Given this list of marker genes BMAL1, HDAC3, KIF2C, GADD45A, PRDM11, WIZ, TMOD3, BTG4, ZNRF4, EIF2AK4, RB1, YEATS4, MOS, INHBA, FOXO4, SIRT1, BTRC, RHOB, CEP131, RPS15A, AATF, DR1, ZMPSTE24 (NCBI Gene Id 10269), BUB1 (NCBI Gene Id 699), OOEP, DDRGK1, CALM2, PRPF19, MIR221, RAD9B, TERF2, KANK2, MIR195, RAD9A, SMARCC2, AVEN, PTPRK, INSR, RPRD1B, DYNC1H1, CEP295, SSTR5, KLHL22, DDIT3, ANKRD31, PRC1, RACGAP1, NR2E1, MX2, CDK5, TGFA, CDK8, WDR5, FOXC1 (forkhead box C1), MEIOSIN, TTK, NEK2, ATM, PRPF40A, WEE2 (NCBI Gene Id 494551), NEK10, RAB11FIP3, TP53BP1, PKD2, MIR519D, SPAG5, NDC80, MACROH2A1, MSX2, MIR892B, VPS4B, RBM46, FOXG1, BCL6, SASS6, USP2, TMEM8B, TFDP1, MIR15B, APBB1, CCNE2, FGFR1, E2F8, HNRNPU, DYRK3, CTBP1, CDC45, FAM107A, SENP6, OBSL1, MIR520H, MAD2L2, GPR132, ADAMTS1, TIPIN, TPRA1, RAE1, KIF23, STOX1, ZNF703, BABAM2, PSME3, PTEN, AMBRA1, CCPG1, ZWILCH (NCBI Gene Id 55055), CDC25B, EDN1, KNL1, DOT1L, ZNF207, CSNK2A1, PPP1R15A, ZFYVE26, TICRR, MIR29C, SKA1, MBLAC1, RAD51B, ERCC6, MIR372, TOPBP1, CLTC, MRFAP1L2, GIPC1, PLCB1, EXOC7, CDC73, TADA2A, PRDM9, RCC2, TBX3, CABLES1, NOP53, IQGAP1, MEPCE, INSM1, HMGA2, BCL7C, OPN1LW, CAMSAP3, ITGB1, SLF2, MEIOC, INIP, ACTL6A, MAPK14, TBRG4, RGCC, BID (BH3 interacting domain death agonist), SOX2, RBM14, PIK3C3, PTPRC, TACC3, KLF4, RRM2, KAT5, PCLAF, CDKL1, ALOX15B, CHMP5 (NCBI Gene Id 51612), ASAH2, NEK6, MBTPS1, ZBTB49, SPICE1, PKP3, BRCA2, EIF4G2, MSH2, EIF4E, CEP76, YTHDF2, MIIP, BMP4, TAF6, JADE3, PRKACA, APPL2, TXLNG, ARF6 (NCBI Gene Id 63379), GMNC, ESX1, SH2B1, GPNMB, SLC6A4, SPATA22, SMARCD2, YY1, SLFN11, SCAND3 (NCBI Gene Id 114821), CCSAP, DLGAP5, GPR15LG, TOM1L1, CCDC8, TOM1L2 (target of myb1 like 2 membrane trafficking protein), FBXO4, FZD3, CKS2, USP19, PIK3R4, AHCTF1, RPS6KB1, NAE1, EVI2B, INO80E, NPPC, TAS1R2, PPP2CA, PHACTR4, PPM1A, CDKN3, CCDC66, WDR12, MAPK12, SND1, OR2A4, TMEM67, MAP3K7, FSD1, FBXO31, NR4A1, WNK1, TRIP13, E2F7, FEM1B, CCNL1 (cyclin L1), NCAPD3, RAD21, FANCD2, KIF20A, STAT5A, INO80, CDKL4, INTS13, CDC25A, YTHDC2, CCNY, ING4, CEP295NL, CHMP1B, HRAS, NPM1, RANBP1, TBX20, BIRC2, CDKN2D, CDK5RAP1, BCL2, MAP10, IER3, GLI1, FAM83D, RRM2B, CETN2, ZZZ3, CDC20, DDB1, CKS1B, RAD51AP1, GFI1B, CDC16, SOX9, PDCD6IP, MEIS2, JUNB, SMC6, BUB3, LRP5, MIR424, CAV2, TAL1, RPTOR, CDK15, SMARCA5, SMARCD1, SHB, KIF11, SIPA1, SMARCA2, IL1A, INO80D, CDK11A, ARID1B, LGMN, TAOK2, GPSM2, CD28, DMRT1, TENT5B, CDK2AP2, PES1, BCL7B, E4F1, HORMAD1, PRKAG2, BEX2, BRSK1, CHMP2A, RBM38, RAD51, MAD2L1, ANKRD17, MN1, TP63, CCNH, SUSD2, CCNG2, CUL4A, CEBPA, VASH1, OPN1MW, HUS1, CUL9, CLSPN, KIF14, POC1A, ZNF16, FEN1, MASTL (microtubule associated serine/threonine kinase like), CCNQ, TRIM32, KCNA5, HTRA2, STAT5B, KCNH5, NAA10, UBE2B, CDK16, SETD2 (NCBI Gene Id 84184), MAGEA5P, TMSB4X, SENP2, RUVBL1, RNF4, STK11, ASCL1, MECOM, RPA3, HOXD10, ENSG00000266560, ZNHIT1 (zinc finger HIT-type containing 1), FNTB, KLHL13, FBXW5, MIR208A, RBL1, MIR137, CHMP3, EGFR, LYN, ESPL1, EML3, PLK3, SMARCC1, NANOS2, MOK, PLSCR1, ANAPC16, DMAP1, ANAPC13, PLAGL1, XPO1, RMI2, MIR133A1, ANKRD53, EZH2, BAP1, PDGFB, ADARB1, TP53BP2, SFN, NCAPG2, CEP250, CCAR2, C9orf78, PKN2, TAF1, SPAST, FGF10, BCL2L1, SPC25, CNTD1, MEAF6, CHMP7, C10orf90, SKA3, BIRC7, LEP, FOXE3, DAB2IP, TP53I13, HPGD, NR4A3, TSC1, MUC1, STK38, GAS1, NUDT6, BARD1, SFPQ, SKP2, CCND3, PROX1, E2F1, MIR26A1 (microRNA 26a-1), BOP1, ANKK1, PAGR1, TRIM35 (tripartite motif containing 35), THAP1, MAP9, WAPL, INCENP, DGKZ, CRNN, PRNP (NCBI Gene Id 96713), TP73, TRIM37, CDK13, MIR495, PPM1G, RAD23A (RAD23 homolog A, nucleotide excision repair protein), TTC28, PRKCE, ETS1, STK35, NFE2L1, PDE3A, PTPN6, BAZ1B, TRIM21, STK33, FBXO43, HSPA1B, MIR29A, RFPL1, CUL3, CDK9, HUS1B, BRD7, PAXIP1, EPC1, SIRT2, FBXO6, SIN3A, ING3 (inhibitor of growth family member 3), AURKA, PARP3, HCFC1, PKP4, CEP85, RHOA, CHMP1A, KIF13A, MIR638, CALM3, TCIM, RARA, RIPOR2, PSME1, NABP2, CDKN2A, BRD8, MIR19B1, WDR76, FAP, CREB3, INS, DACH1, CSNK2A2, MYC, ZC3H12D, CDK1, RAD50, PTK6, DPF2, ACVR1, RPA4, MAP2K6, ANAPC1, CXCR5, CTDSPL, DNA2, PRKCA, L3MBTL1, PHOX2B, PSMD10, BRINP1, PIM2, CENPE, VPS4A, YY1AP1, RRP8, PLK5, NUGGC (nuclear GTPase, germinal center associated), DPF1, NUSAP1, DTL, NANOGP8, MLF1, NCAPH2, NF2, FOXA1, CDKN2C, GNAI1, GPR3, HES1, SUV39H1, ATAD5, ANAPC7, ANGEL2, CHORDC1, BRCA1, DRD3, ACTB, BORA, CDKN1A, HSPA1A, CENPJ, ETAA1, PRKAG1, RRM1, SOX15, MRE11, NME6, NEK9, NUPR2 (NCBI Gene Id 442546), GAS2, DUSP3, PPP2R3B, PPP2R1A, CTC1, NCAPG, UHRF2, MIR10A, NUPR1, CDK6 (cyclin dependent kinase 6), SDE2 (NCBI Gene Id 163859), APBB2, KHDRBS1, RAD51C, ID2 (inhibitor of DNA binding 2), FBXO5, PRMT5, BIRC8, KAT2B, TCF3, CDK2, THAP5, YWHAE, FZR1, SCRIB, MDM4, NAT10, WNT10B, MAP3K20, PRCC, BRCC3, PRKAG3, ACTR8, CCDC15, MTA3, BAX, WAC, BLM, APC, LEF1, MIR34A, GNB1L, CDK20, USP44, CYP1A1, TFDP2, MIR133B, DDR2, VPS72, TRRAP, MIR30C2, SON, MIR193A, PAF1, CDK12, CDKN1B, TP53, CGREF1, CTDSP1, CITED2, UIMC1, NFRKB, SPDL1, TSG101, HOXC9, BCR, CABLES2, RHEB, TRIM39, PTENP1-AS, PKIA, ATXN10, CCNB1, SIK1, ATF2, MBTD1, PLK4, DUX4, ZPR1, CDK4, HSP90AB1, AURKAIP1, CTDSP2 (CTD small phosphatase 2), ZNF830, POLDIP2, ZBTB17, TRIAP1, INTS3, EP400 (E1A binding protein p400), MKI67, MYO16, ATP2B4, MUS81, SYF2, DYNC1LI1, HINFP, INTS7, CUL7, HASPIN (histone H3 associated protein kinase), TIMELESS, UBA3, CSPP1, ABL1, STRA8, DAZL, PHIP, CCNL2, EGF, PRR11, MTBP, HSF1, MIR26B, SMC2, TMEM14B, RXFP3, CDT1, CACNB4, PIWIL2, MRGPRX2, PDXP, ATRIP, DLG1, MORF4L1, PTPN11, NUP214, SMIM22, KNTC1, CDC6, FBXW7, INO80C (NCBI Gene Id 125476), C6orf89 (NCBI Gene Id 221477), ACTL6B, CCND2, OR1A2, ROCK2, CALR, IK, ASPM, MADD, ECD, METTL3 (methyltransferase 3, N6-adenosine-methyltransferase complex catalytic subunit), TGFB1, WNT5A, OPN1MW2, ATF5, HLA-G, MCIDAS, WEE1, OVOL1, TTLL12, BIRC3, PLK1, PRMT2, NEUROG1, PLK2, NEK11, PPP2R2A, CDC14C, GEN1, LRP6, WDR62, IFNW1, AICDA, CDK5RAP2, TSC2, BUB1B, USP16, MBIP, RACK1, LATS2, TFDP3, RNF112, PPP1R13B, MARK4, TTI2, RPA2, CCL2, KLHL18, BRINP3, CDKL3, MIR503, NKX3-1, KIF25, LIN9, MRGBP, BIRC6, LIF, SGF29, BCL2L11, SMARCB1, PKHD1, MNT, MED1, PUM2, ECT2, NUP62, KIF20B, RBL2, SPC24 (SPC24 component of NDC80 kinetochore complex), USP28, DRG1, PTPN3, ORC1, CHMP6, LSM10, RAD1, GATA3, UCHL5, TSPYL2, ZFP36L2, TRNP1, SMPD3, MDM1, RUVBL2, PPP2R2D, BAK1, CDKL2 (NCBI Gene Id 8999), SMC4, PIM3, BCL7A, XIAP, KMT2E, DRD2, RNF40, TNKS, NCAPH, LFNG, ANLN, UBXN2B, MAGEA4, NSFL1C, IRF1, CCNK, GRK5, PKMYT1, CDK11B, NLE1 (notchless homolog 1), NHERF1, CIT, LSM11, TEX14, CYLD, MYOG, MORF4L2, NUMA1, MAD1L1 (NCBI Gene Id 8379), DCDC1, NABP1, CDCA8, CASP3, NANOS3, BIN1, RDX, DDIAS (NCBI Gene Id 84145), FGF8, NLRP2B (NCBI Gene Id 286430), DUSP1, ABRAXAS1, CCNF, MCPH1, CDC42, MEN1, PIM1, USP22, CHMP4A, OVOL2, AURKB, ZNF268, ARID1A (AT-rich interaction domain 1A), CEP63, PUM1, SPHK1, CCDC57, RBBP8, RPRM, RAD18, SRPK2, UHMK1, BABAM1, EIF4EBP1, ALMS1, PHF10, TPR, MIR200B, SFRP1, RAB11FIP4 (NCBI Gene Id 85018), ANAPC2, SMC5, ZFYVE19 (NCBI Gene Id 84936), KIF2B, HOXA13, BMP7, FIGNL1, WNT4, GIGYF2, CCP110, TFAP4, ZW10, BRD4, CDC23, CRLF3, BBS4, DONSON, MCRS1, ZWINT, FOXN3, MAEA, KNSTRN (NCBI Gene Id 90417), BRINP2, RUNX3, TPX2, UVRAG (UV radiation resistance associated), POU4F1, STAT3, MAD2L1BP, NPM2, MARK3, CDK3, PSMA8, GMNN, CDC26, AKT1, SIX3, COPS5, PPP1R10, CHMP4BP1, ASNS, BECN1, TTL, UFL1, EDN3, FGF2, PML, MIR134, PDIK1L, PIN1, ADCYAP1, TADA3, MNAT1, PBRM1, AFAP1L2 (actin filament associated protein 1 like 2), RAB6C, ANAPC5, BIRC5, AKT2, SH3GLB1, FOXM1, SETMAR, MIR515-1, EIF4G1, GIT1, TAS2R13, DBF4B, PSMG2, TERT, TFPT, ERCC2, RAB11A, CHEK2, NUBP1, SMARCD3, AIF1, HBP1 (NCBI Gene Id 26959), CGRRF1, NSMCE2, DBF4, INHA (NCBI Gene Id 3623), AXIN2, DPF3 (NCBI Gene Id 8110), FHL1, CALM1, CHMP4B, USP50, RASSF1, UBE2E2, CDC14A, KLHL9, SMOC2, NSUN2, EME2, MIR362, ANAPC10, YEATS2, TARDBP, TNF, MIR29B1, CDKL5, MRNIP, PPP1R9B, CHFR, UBD, STXBP4, CENATAC, ZFP36L1 (ZFP36 ring finger protein like 1), PBX1, PARP9, NEK7, PKD1, E2F2, ANAPC4, TBRG1, RINT1, KAT14, INO80B, FGFR2, CUL4B, HEXIM2, MIR873 (NCBI Gene Id 100126316), TERF1, ANAPC11, TELO2 (NCBI Gene Id 9894), ERCC3, USP17L2, KAT7, GBF1, GPER1, PPP1R35, PRAP1, JUND, FZD9, TRIM36, PER2, NUF2, DDX11, SLF1, PSRC1, JADE2, CEP97, GADD45B, ACTR5, ING5, PABIR1, XPC, CENPV, MIR590, CHMP2B, RCC1, RAD51D, LCMT1, SMARCE1, TGFB2, TREX1 (three prime repair exonuclease 1), TBX2 (NCBI Gene Id 6909), TGFBR1, TM4SF5, MIR451A, PLCG2, CDK19, CDC5L, DYNLT3, APPL1, ADAM17, MIR520A, PRP4K, C4orf19, IL10, FBXO7, CCND1, RPS27L, CDK17, CDKN2B (cyclin dependent kinase inhibitor 2B), KLHL21, PDGFRB, MDM2, BTG3, CDK10, HECW2, CDK14, DCUN1D3, RIOK2, CTNNB1, KIF3B (kinesin family member 3B), HSPA2, HIPK2, MIR214, DAPK3, RNF167, CHMP4C, CDC7, RNASEH2B, RPL23, IHO1, TGM1, CENPF, SKIL, INCA1, CTCF, EPGN, LILRB1, CDK5RAP3, IGF1, CPSF3, EREG, PAFAH1B1, TIPRL, MIR16-1, CDK18, H2AX, CRY1, NUDT16, POC1B, HEPACAM, MIR222, TP53INP1 (NCBI Gene Id 94241), CDK7, ANXA1, CEP120, XRCC3, RFWD3, ATRX, DCTN1, DACT1, GTPBP4 (NCBI Gene Id 23560), USP51, PSME2, PTCH1, INSM2, MIR15A, ATR, IPO5, RHNO1, IL1B, ARID2, IGF2 (NCBI Gene Id 492304), BRIP1, SVIL, LATS1, UBE2C, TSC22D2, BTN2A2, MBTPS2, EPC2, AURKC, TTI1, SMARCA4, NPR2, MIR21, BTC, SDCBP, MAPK15, PPP2R5B, TAOK3, TAOK1, RAD17, CCNE1, JUN, BMP2, APP, PLRG1, CHEK1, CDCA2, NCAPD2, SGSM3, ZNF655, RPS6KA2, PRKDC, CDCA5, MYO19, MDC1, EME1, RNF20, STIL, KAT2A, MYBBP1A, CDKN1C, GADD45G, CLOCK, KLF11, CSNK2A3, MSX1, CDC27 (cell division cycle 27), DDX3X, ANAPC15, NBN, HECA, ENTR1, CDC25C, PINX1, EPM2A, POC5, IPO7, JADE1, DTX3L, CDC14B, here is a description of the gene set: studied in species Homo sapiens Human Gene Set: GOBP_REGULATION_OF_CELL_CYCLE Any process that modulates the rate or extent of progression through the cell cycle.